The following is a description of a gene set: species: Mus musculus Mouse Gene Set: GOBP_MESODERMAL_CELL_MIGRATION The orderly movement of mesodermal cells from one site to another., and this is the list of marker genes: Mesp2, Fgf8, Apela, Lrp5, Epb41l5, T, Lrp6, Mesp1, Nckap1